The following is a description of a gene set: species: Homo sapiens Abnormal increase or decrease of cytotoxic CD3+CD8+ T cells, measured as percentage of total CD3+ T cells in the blood, compared to a reference range for a given sex and age-group. These are usually measured within the TCR alpha/beta positive population. Abnormal CD8+ T cell proportion Human Gene Set: HP_ABNORMAL_CD8_T_CELL_PROPORTION, and this is the list of marker genes: PGM3, CASP10, IL2RG, EXTL3, CD3G, NSMCE3, FASLG, IL7R, IRF1 (interferon regulatory factor 1), CARD9, PIK3CG, CD8A, IKBKB, TCF3, FAS, ZAP70, BLM, WAS, SASH3, WIPF1